Given this list of marker genes Phtf1, Acod1, 9330179D12Rik, Azin1, Elp5, Ptch1, Rdm1, Ppfia4, Wnt1, Gpr4, Lrrc8d, Hnrnpul2, Acaa2, Gosr2, Larp1b, Cuedc2, Ifnar1, Gm16046, Fis1, D16Ertd472e, Slamf6, Relt, Rcbtb2, Kctd17, Psmb9, Rin3, Sh2b3, AW112010, Ddx4, Tnfaip8l1, Cnbd2, Elovl6, Pef1, Prss50, Nlrp1b, Prrc2c, Zfp111, 9530036M11Rik, Ccl3, Birc3, Pcnx3, Hnrnpdl, Lcp2, Fam171a2, Ulbp1, 2310044K18Rik, Cd68, Mir5619, P4ha1, Tagap, Erbin, Pip5k1a, Zeb1, Fcgr4, Scand1, Jak2, 1700011B04Rik, H2-T10, Psap, P2ry6, Itpkc, Nfkbiz, Axl, Hnrnpc, Gm20121, Sema3b (sema domain, immunoglobulin domain (Ig), short basic domain, secreted, (semaphorin) 3B), Wdr70, Grk3, Cdk12 (NCBI Gene Id 69131), Stk10, Slc15a3, Mir7671, Zfp84, Rps27a, Cask, Lasp1, Csrnp1, Gm6034, Oaz1, Sbf2, Bfsp2, Phf11b, Eml6, Polg2, Gm8869, Sema4d, Slamf8 (SLAM family member 8), Nipal3, Smarca2, Or2d2b, Fhad1, Ints7, Ugt1a7c, Gpr68, Far1os, Gramd2a, Hmcn2, Gm12156, Cacna1s (NCBI Gene Id 98698), Snora78, Slc35b2, Tnf, Atic, Ripk2, Gbp3, Mcl1, Rfxap, Gm10044, Dot1l, Ehf, Gm16712, Ncf1, Lacc1, Mlxip, Dagla, Aasdh, Gpr176, Cltc, Gpr85, Sfr1, Cdkn2d, Gm11476, Ints6, Sdc4, 1700009J07Rik, Gm14199, Gm28347, C1qa, Leprotl1, Sde2, 2810454H06Rik, Il1a, Arid3b, Klrb1b (killer cell lectin-like receptor subfamily B member 1B), Ell3, Gpr18, Phf23, Furin (NCBI Gene Id 78149), Nup93, Glipr1, Plekhh1, Rbm5, Ppp1r11, Laptm4b, Drap1, Gm24916, Fcgr3, Or1j22-ps1, Fads2, Or5v1, Ms4a1, Kcnh4, Ica1, Zfp800, Gm15545, Styk1 (NCBI Gene Id 243659), Itgb1bp2, Slc12a2, Cd74, Camk2a, Slc39a13 (NCBI Gene Id 68427), Rnase6, Rnasel, Neat1, Tnpo1, Braf, 4933439C10Rik, Nfatc2, Ccl2, Foxp4, Serpinf1, Gm4189, Pik3r5, Plekha2, Fyb1, Stx11, Bcl2a1b, Vwa5a, Snord19, Kif1a, Tmcc3, Ly86 (lymphocyte antigen 86), Btg2, Vgll4, Tlr12, Slc23a4, Rab11fip1, Atxn7l1, Cxcl11, Ubash3b, Clec9a, Ccl4, Gm19684, Csf2, Hspa13, Gm10384, Mir6935, Mageb3, Ube2d2a, Xpo4, Serhl, Nqo2, Mbnl1, D5Ertd579e (NCBI Gene Id 77811), 1810009A15Rik, Tdrd5, Ctsh, Gm6054, Gm22581, Msh6, 1700055D18Rik, Lamp1 (NCBI Gene Id 234071), Wfdc21, Tufm, Rnf170 (NCBI Gene Id 77733), Eny2, Tbk1 (TANK-binding kinase 1), P2rx5, Snx8, Stap2, A530040E14Rik, Ptpn3, Hivep1, Mir1932, Mrpl17, Wsb2, 4833418N02Rik, Stxbp1, Haus8, Agrn, 6530409C15Rik, Pcdh15, 4933437G19Rik, 4921524J17Rik, Cln3, Inpp4a, Itga5, Pgap6, Sbds, Pdzd9, Ifi204, Erich3, Adgre5, H2-Eb1, Gm6377, Kansl1, Slk, Atp5pd, 1110019D14Rik, Chaserr, Nadk, Casp4, Gm13310, Ier3, Trbv10, Borcs6, Gna15, Ncf4 (neutrophil cytosolic factor 4), Tgif1, Slc30a3, Thap6, Trp53, Mcemp1, Cd300lf, Nudt17, Dusp5, Cxcl10, Bmf, Tfeb, Vamp4, Or11i1, Irag2, Gsr, Lyrm2, 4930580E04Rik, Sh2d1b1, Ifi211, Bcl2l1, Irf2, Bcl10, Serpina3g, Nrg4, Cd40, Dpep2, Gm15889, Itgax, C1qc, A930005H10Rik, 2210011K15Rik, Tlr3, Asap1, Ifnb1, Gm23723, Mef2c, Gm13281, Elmo2, C1qb, Tlcd2, Tlr2, Kynu, Slfn8, Gbp5, Cd83, Gm16433, Gm23229, Gm25855, Cfap54, Stn1, Trex1, Mir6361, Dapp1, Dync2h1, Parvg, Mir142hg, Ptpro, Cystm1, Fam216a, Gm16675, Mir16-2, Mapk6, Asgr2 (asialoglycoprotein receptor 2), Fnbp1, Ptp4a1, Cd69, Trbv13-1 (T cell receptor beta, variable 13-1), Fgf9, Apobr, Kif21b, Urm1, Myc, Krcc1, Septin9, Gm23205, Oas3, Gm12227, H2-K1, Serpina3f, Kctd12, Rassf2, Ppp1r12b, Mrtfa, Mir191, Tesk2, Golgb1, Tmem128, Gm20513 (NCBI Gene Id 105245179), Gpatch2l, Klf10, Blnk, Adgb, Men1, Ppip5k2, Pheta2, Cct5, Ywhaz, Syk, Clec12a, Gm25443, Col6a5, 1110002J07Rik, H2-DMb2, Mmp9, Gm15573, Fgr, Bri3bp, Ifit1bl1, Erc1, Parp11, Cir1, Tmem106a (NCBI Gene Id 74806), Calhm6, Spcs2-ps, Rnd1, Mrpl18, Dph5, Supv3l1, Gm14881, Ibtk, Evi2a, Gm20443, Oasl1, Kmo, Mndal (NCBI Gene Id 192690), Rangap1, Zfp62, Tank (NCBI Gene Id 97021), Sh3bp2, Il10rb, Osbp, Cpeb3, Tlr9, Jak3, Rnf213, Clec7a, Alg13, 4930539J05Rik, Mtmr14, Igkv13-82, C1galt1 (core 1 synthase, glycoprotein-N-acetylgalactosamine 3-beta-galactosyltransferase, 1), Lair1, Fbxl3, Il1r2, 5830418P13Rik, Mon1b, Rps15a-ps5, Tcof1, Cep350, Lilra6, C3ar1, Anxa4, Srrt, Mir9-2, Itga6, Sec62, Med11, Gm1976 (predicted gene 1976), Xaf1, Gm2673, Cd24a, Nfkb2, Gm15628, Cfap77, Lrch3, Kansl1l (NCBI Gene Id 98336), Nfkb1, P2ry14 (purinergic receptor P2Y, G-protein coupled, 14), Srd5a3, Ndufaf3, Arhgef40, Zbtb18, Cd80, Anapc1, Ppp1r18, Zfp429, Tlx1, Gm6162, Cytip, Ino80c, Relb, Gm18294, Nudt13, Mir5130, Bcl3, Gmfg, Dap3, Or10aa3, Il33, Rasd1, Aebp2, Nsmaf, Gm24978, Parp8, Tradd, Cops7b, Slc16a6, Rilpl2, Slc14a1, Rbpj, Evi2, Id1, Psat1, Msl1, Gm15471, Adra1a, Fam168b, A930028O11Rik, Klhl6, Ms4a4c, Gm18635, Sun2, Slc11a1, 9130401M01Rik, Cyp27a1, Arrb1, Nr2c2ap, Runx1, Ptk2, Letm1, Blvrb, Nup160, AU015336, Slc9a8, Akap10, Mir7683, Gm9920, Mfsd11, 2210417A02Rik, E2f8, Rabgap1, Ifi205, Wnt6, Spdl1, Plagl2, Myl4, Sptan1, Gyg1, 2310001H17Rik, Nek6, Ccdc134, Zmynd15, Anxa5, Ifrd1, Tnfrsf1b, Usf1, Or5b113, Tmem200b, Gm18995, Isg15, Arhgap27, Inka1, Eif4g2, Syne2, Maco1, Lrrk2, Bcl9, Ucp2, Pdss1, Zbtb20, Uap1, Hax1 (NCBI Gene Id 23897), Tbc1d14, Tnfrsf14, Sumo3, Gm37359, Efcab9, Tnfsf9, Srgn, Ttll4, Ccdc71, Clec4a4, Spop, H4c12, Hc (hemolytic complement), Uhrf1, Rhog, Upf2, Tpr, R3hcc1l, Cyp7b1, Prkcd, Zc3h12c, Dynlt4, Galnt1, Actr3, Dleu2, Ccdc88b (NCBI Gene Id 78317), Ift80, Cd82, 4930579G24Rik, Gnl3, Mir7009, Fam20c, Gm15987, Prdx5, Zbtb7a, Oxsm, 2310010J17Rik, Smdt1, Stk25, Wrnip1, Asxl1, Slc23a2, Rnf122, Wdfy3, Gbp2, Cep131, Prr14, Zfp513, Dnah2, Htr7, C920021L13Rik, Zc3h7a, Gm9637, 4930456G14Rik, Gm6410, Nuggc, Fam111a, Map3k5, Commd8 (NCBI Gene Id 97223), Itpripl1, Synj1, Cd84 (CD84 antigen), Tuba4a, Atp2a2, Clec5a, Slc18a1, Plat, Klk1b16, Extl2, Noct, 1810062G17Rik, 4930578M01Rik, Niban3, Ppfibp1, Myd88, Mindy3, Ift140, Ttc7, Tgtp1, Abtb3, Tcstv6a, Rnf13, Picalm, Gm8369, Tpd52, Icam1 (NCBI Gene Id 235038), Nfkbie (nuclear factor of kappa light polypeptide gene enhancer in B cells inhibitor, epsilon), Tomt, Tnip3, Nfia, Manba, Gm43380, Car13, Nvl, Ifna2, Zdhhc21, Gtpbp1, Dbnl, Zfand2b, Adam34, Ptpa, Dnajc12, Arf4 (NCBI Gene Id 30916), 5730522E02Rik, Flt4, A530010F05Rik, Ccdc122 (NCBI Gene Id 71108), Lrrfip1, Abl2, Eif4enif1, 9430069I07Rik, Dhrs9, Gm16576, Pira12 (NCBI Gene Id 18730), Map2, Six5, Gm7008, Chp1, Gypc, Cep162, Vps9d1, Gm26535, Cntnap5c, Tcf19, Slamf9, Irf1, 5031425F14Rik, Amz1, Col15a1, Cst3, Tex30, Itga4, Shc4 (SHC (Src homology 2 domain containing) family, member 4), Rel, Dennd4b, P2ry12, AW495222, Tapbpl, A3galt2 (NCBI Gene Id 215493), Gbp9, Phf14, Esyt3, Gm12764, Atp8b4, Ube2e3, Tcf7l2, Ift57, Denr (NCBI Gene Id 68184), Atat1, Tmem39a, Arnt, Gm19345, Gpr33, Rfx5, Ccnh, Yjefn3, Chd4, Cd53 (CD53 antigen), Txnip, Zfp91, Sp110, Tmem192, Rnu7, Tmem131l (transmembrane 131 like), Zfp622, Map3k7, Cybb, Pitpnm1, Bach2it1 (BTB and CNC homology 2, intronic transcript 1), Dcaf11, Tapbp, Hells, Pecam1, Cbx1 (NCBI Gene Id 319869), Fcer1g, Rpgrip1, 4833439L19Rik, Mirt1, Mir425, Casc3, Cfb, Nfam1, Itgb1, Cyp4v3, Ly6e, Dmpk, Xcr1, Gm6209 (predicted gene 6209), Sec61a2, Atp6v0a1, Gsto2, BC035044, Nfu1, Pde4c (NCBI Gene Id 270056), Poli, Or6k2, Zfp36l1, Manbal, Zeb2os, Lbhd1 (NCBI Gene Id 102308570), Kif23, Btla, Gm13449, Gm33366, Dek, Trim56, Bend6, Cxcl9, Eif2ak3, Zbtb38, C5ar2, Ccdc50, Lrp10, Chid1, Trbv12-1, Ido1, Rbbp7, Rhoh, Gm15730, Mir6392, Tanc2, Hk1os (hexokinase 1, opposite strand), Zc3hav1, Sh3glb1, Ubl7, Pacs1, Mpdu1, Arih1, Gm2895, Amer1, Fam8a1, Smim35, Tcp1, Bbc3, Tmt1a, Norad, Or6k3, Pik3cd, Cfap126, Gm40323, Actg1, Phlpp1, Ms4a7, Pik3cg, Nr1d2, Capg, Sval1 (seminal vesicle antigen-like 1), Kif5c, Smad5, Arl10, Napsa, Timm44 (NCBI Gene Id 76268), Hk1, Gm10521, Cebpg, Nlrp3, Pacc1, Cchcr1, 2610037D02Rik, Pwp1, Ms4a6d, Pias3, Spag9, Ehd1, Socs4, Dhx40, Rabgap1l, Il6ra, Cnp, Prnd (prion like protein doppel), Slamf7, Ccne1, Cetn4, Atr, Ccl17, Fus, Mir142, 1700003M07Rik, Pknox1, Zc3h12a, Ms4a14, Gbp4, Slc45a3, Cdh13, Slc26a11, Gm26608, 1700067G17Rik, Rela, Prkar2a, Rad52, Ctdspl2, Gm13748, Emp3, Dcun1d5 (NCBI Gene Id 76863), Il27, Mtmr4, Ptprv, Slc17a5, Exoc3l4, Elmod2, Iscu, Cep128, Pheta1, Sh2d6, Galnt10, Isg20, Vmp1, Map4k2, Inf2 (inverted formin, FH2 and WH2 domain containing), St8sia4, Hsd17b11, Snora57, Lrp1, Lrp11, Hdgf (heparin binding growth factor), Dglucy, Gm7461, Ascc2, Gpr141b, Tdg, Tamalin, Cfap61, Notch2, Mir6539, Rnf38, Clec2d, Tmem229b, Ift52, Opn3, Mir6953, Slc13a1, Rmi1, Sulf2, A530072M11Rik, Rps2, Arhgap30, Plekha4, Ilk, Endod1, Sfmbt1, Sri, Gckr, Mir8112, F830208F22Rik, Stxbp3, Il1b, Zmym6, Ccdc186, Ikbip, Lyrm1, Il7r, Chd2, Tmem258, Gm13814, Nox1, Cdkn1a, Tlr5, Ccrl2, Susd3, Mir155hg, Milr1, Gm15706, N4bp3, Cfp, Plekhh3, Il6, H2-M2, Rassf5, Lgals9, 4833445I07Rik, Mt1, Dnal1, Tspan8, Tcirg1, Gm28707, Mx2, Pisd, Gripap1, Mir7014, 1700065D16Rik, Endov, Akap13, Gm26183, Mir9-2hg (NCBI Gene Id 72677), Gm15848, Rgs9, Fcrl1, Clec4b1, Gm12185, Tcea1, Shisa5, 6430571L13Rik, Fndc3a, Gna13, Ifi207, Slc30a7, Lzts2, 1700113A16Rik, Ccdc107, Pfn1, Gpn3, Ptgs2os2, Vcam1, Tmigd3, Tpm3, Mmp25, Smc4, Foxh1, Clec4a2, Bhlhe40 (basic helix-loop-helix family, member e40), H2-Q4, Zhx2, Dock10, N4bp2l1, Mrpl13, Tab2, Marchf1, Rheb, Odr4, Gpr89, Rab7b, Bank1, Cd44, Ifih1 (interferon induced with helicase C domain 1), Serpinb9, Snx10, E230013L22Rik, E230016K23Rik, Anapc13, Lrrc25, Ifngr1, Ecm1 (NCBI Gene Id 99700), Sec22a, Gm26358, Kcng3, Ncoa7, Cxcl16, Gm9694, Mfsd1, Il23a, Fbxo7, Tasl, Cdca2, Klhdc8b, Mrps21, Vsir, Nuak2, Ccl5, Rsl1, D430040D24Rik, Apol10b, Nxf1, Jag2 (jagged 2), Srgap2, Gm14018, Tubb5, Ikbke, Nr6a1, Mir155, Bdp1, Tmem116, Gpbp1 (GC-rich promoter binding protein 1), Mtrf1l, Tm2d1, Srsf2, Rpia, Gm16299, C2cd3, Lrch4, Hsp90aa1, Dlgap4, Fcgr1, Gbp7, Foxj2, Tlr11, Or10v9, Ints5, Gm15663 (predicted gene 15663), Dmwd, Etv4 (ets variant 4), Traj47, Gstp3, Il12b, Gm26628, St3gal3, Sh3tc1, Snx11, Zbtb10, Oard1, Eml4, Or5k8, Atp8a1, A930012O16Rik, Nek8, Pnpla3, Grcc10, Col17a1, Gm17089, 4933433G15Rik, Ms4a4a, Srsf5, Gm13022, Map3k8, Sh3bp4, Slc2a6, Clec4a1, Sh3bp1, Ifnlr1, Cbll1, Ldlr, Mir8090, Rnf31, Tns3, Gm7804, Mogat1, Mir7045, Madd, Rigi, 2700097O09Rik, Mis18bp1, Setd1b, Tmbim6, Psme2, Hk2, Irf8, Scarna17, Mapk1ip1l, Med21 (NCBI Gene Id 97336), Ifi202b, Erich1, A630081D01Rik, Gm336, Zkscan17, Slc22a15, Pla1a, Bmal1, Fcmr, Trim25 (NCBI Gene Id 22660), Sema4a, 9530082P21Rik, Creb1, Tnni2, Ext1 (NCBI Gene Id 14042), Hepacam2, Crtc2, Synpo (synaptopodin), Marveld1, Gm43351, Optn, Fancc, Gtpbp6, A730061H03Rik, Gabpb1, Lrch1 (leucine-rich repeats and calponin homology (CH) domain containing 1), C630043F03Rik, Mir22hg, Mir5136, Cdc42ep4, Tnfaip3, Pdyn (prodynorphin), Nrxn2, Tnfsf15, Nup85, Psen2, H2-M3, Xpnpep1, Susd6, Mgat5, Sh3bp5, Gpatch2 (G patch domain containing 2), Plgrkt, Gm13546, 1700041G16Rik, Tm9sf4, Ccnl1, Pde8a, Coprs, Gm7882 (NCBI Gene Id 665994), Gm35986, Grn, Arap1 (NCBI Gene Id 69710), Klrk1, Serpinb12, Ccl22, Nfkbib, Tbc1d1, Gm10293, Ddx59, Atp6v0a2 (ATPase, H+ transporting, lysosomal V0 subunit A2), Txn1, Tlr4, Or10aa1 (olfactory receptor family 10 subfamily AA member 1), Kctd13, Amz2, Atf3, Dusp6, Fblim1, Ccdc73, H2-Ob, F730311O21Rik, Fen1, 1700066B17Rik, Chchd1 (coiled-coil-helix-coiled-coil-helix domain containing 1), Gm37294, Gfi1b, Gpr19, Ankhd1, Pde7a, Zfand2a, Rgs7, Map3k14, Trim7, BE692007, Treml4, Kat5, Gm28809, Arl5b, Sirt2, 2410002F23Rik, Egln2, Katna1, Sema4c, Lmna, Ptdss2, Gm28777, Bcl2a1a, 4930551O13Rik, Mtbp, Phlda1, Tpd52l2, Gm13073, Schip1, Stpg1, Gm20605, Pex2, Traf1, Chrac1, Tiparp, Per1, Rasa4, Rara, Klra17, B3galnt2, Fabp9, Gm23119, Acot7, Cysltr1, AY512931, Smap1, Rapgef2, Polm, Frmd4b, Esrra, Zfhx2, Ctsz, Tle1, Ube2k, Ahcyl2, Frmd8os, Tor3a, Zfp217, Il16, Hnrnpu, Crnkl1, Cyfip1, Gm14221, Myh9, Gm26766, Ndufa13, Naa15, Raf1, Cyld, Cxcl2, Hk3, Hint3, Plpp1, Ifi209, Slc6a12, Gm16274 (predicted gene 16274), Mir1938, Rasgrf2, Med13, Gm29040, D930048N14Rik, Batf2, Nudt9, Hnrnpk, Ptprc, Pml, Actn1, Wrap53, Rarb, Tap2, Alkbh5, Gm22504 (NCBI Gene Id 115485615), Jdp2, Vash1, Aff1, Il18rap, Zbtb6, Ppm1m, Timd2, Ptpn6, Irf5, Taf4b, Rac2, Coq8a, E230029C05Rik, St6galnac6, Apol7c, Il4i1, Zeb2, Dipk1a, Cyba, Shank1, Mmp12, Mir374c, AI480526, Gm26202, Stap1, Orai2, Ints13, Mpc1, Dennd4a, Phf11d, Tespa1, Cobll1, Ebi3, Frmd5, Fndc7, Cass4, Ube2d3 (ubiquitin-conjugating enzyme E2D 3), Pde6d, Ivns1abp, Gm26306, Aoah, Gm16214, Mlkl, Mllt11, Alg9, Znrf1, Zswim6, Pot1a, B2m, Plk4, Siglecf, Ptpn2, Tec, Bcl2a1c, Cfh (NCBI Gene Id 192290), Gm10699, Dusp2, A630072M18Rik, Prex1, Gm29707, 9130019P16Rik, Elmo1, Fchsd2, Idh1, Etv6, Rbm19, Sgms1, Gm13267, H2-Q6, Agmo (alkylglycerol monooxygenase), Mier3, Ptpn22, Inpp1, Prkrip1, Scimp, Gpr84, Ptpra, Gm15441, Tfe3, Gm26511, Mink1, 6720483E21Rik (RIKEN cDNA 6720483E21 gene), Gm11292, Ccdc85b, Malt1, Dnajc7, Casp8, Tnip1 (NCBI Gene Id 57783), Slc8b1, Tnfsf13b, P2ry10, Tet2, 1700028N14Rik, Arhgap22, Grhl1, 3300005D01Rik, Camkk2, Ints3, Ralgds, Pinlyp (phospholipase A2 inhibitor and LY6/PLAUR domain containing), Aak1, Nr1d1, Prkar1b, Dennd1b, Mttp, Mamstr, Cmtm7, Mtus1, H2-Q10, 9130008F23Rik, Lpxn, Cyb5a, Slfn2, C030005K06Rik, Mfsd13a, Ppp1r15a, Ccdc33, Snhg9, Nfkbid (NCBI Gene Id 243910), Sla, Pf4, Unc119, Gm20652, Neurl3 (NCBI Gene Id 76530), Ssx2ip (NCBI Gene Id 99829), Gm12708, Chd9, Ptp4a2, Rad9a, Engase, Cd274, Zcwpw1, Psmd7, Zfp367, Aim2, Capza2, Mgat4a, Nfkbia, Snora64, Spef1l, Evl, Rnaseh2b, Ifna14, Snrnp35, Ifitm3, Trerf1, Litaf, Cog4, Nfe2l1 (nuclear factor, erythroid derived 2,-like 1), Polr1f, Hif1a (hypoxia inducible factor 1, alpha subunit), H2-K2, 1700096K18Rik, Ccl12, Gsdmd, Ksr1, Gadd45b, Slc37a2 (NCBI Gene Id 56857), Vars1, Gm10419, Mepce, Pea15a, Dnajc10, Smg1, Ubac2, E2f3, Tmem219, Tg, Ly96, Rgs3, Cdc14a, Adgre1, Tnfrsf10b, Ier2, Mast4, Mab21l3, Adap1, Zfp617, Hs3st6, Gm5475 (NCBI Gene Id 432982), Lrrc8c, Nhlrc3, Glt8d2, Klre1, Pdlim2, Bcl2l11, H2-M6-ps, Hmgb1-ps5, Ago3, Ppm1d, Mir15b, Tap1, Gm27003, Pop5, Ifrd2, Zfp740, Ms4a6c, Rab43, Hfe, Arhgef2, Tbkbp1 (NCBI Gene Id 73174), Zfp958, Mdc1, Polr2a, Gm23615, Plscr1, Zfp456, Zup1, Nme8, Nmbr, Irak2, H2-T22, Hmgn3, Tlr6 (toll-like receptor 6), Itga2b, Ing2, Batf3, Prx, Pigv, Tmem79, Trmt112, Trmt10a, Hdhd2, Nrp2, Mir7228, Bcl2a1d, Fadd, Nbeal1, Gm16578, Tlcd1, Thg1l, Cd86, Havcr2, Gbp8, Plek, Dnajc2, Xrcc1, H2-Q7, Stat3, 9930022D16Rik, Gsap, Zbtb26, Polr2g, Soat2, Tbc1d4, Brd2, Snx17, Dgkg, Tnfaip2, Cd8a, Rmrp, Pax6, Nfya, Oasl2, Enthd1, Sac3d1, Igsf9, Mpnd, Ifi203, Gusb, Pdcd1lg2, Lrrc63, Cnksr3, Dnajc5, Mir7681, Slc37a3, Wdfy4, Rcsd1, Nsun6, Atrnl1, Myo18a, Baz2b, here is a description of the gene set: Mouse Gene Set: REL_ALT_TARGET_GENES from publication Yevshin I, Sharipov R, Kolmykov S, Kondrakhin Y, Kolpakov F (PMID 30445619) Genes containing one or more binding sites for studied in species Mus musculus